Given this list of marker genes Akt2, Erbb2 (NCBI Gene Id 13866), Myo5a, Ap2b1, Stac, Cacng2, Rer1, Musk, Mesd, Stac3, Tnf, Grip2, Acsl3, Stx3, Itgam, Lgals3, Arhgef16, Pak1, Commd1, Itga3, Zdhhc2, Akt1, Snx27, Myo5b, Dpp6, Arpc2, Ezr, Kif5b, Actr3, Slc51b, Gper1 (NCBI Gene Id 76854), Agr2, Rab11fip2, Stac2, Stx4a, Vil1, Epha3, Pik3ca, Tent2, Kcnb1, Chp1 (NCBI Gene Id 80510), Arf6, Necab2, Agrn, Fyn, Crk, Slc5a3, Cln3, Mief2, Cnpy4 (canopy FGF signaling regulator 4), Dlg4, Cemip, C2cd5, Mief1, Prkn, Dlg1, Efcab7, Atp2b4, Hras, Hpca, Mtcl1, Ptpn9, Trem2, Lrp4, Rab11a, Zdhhc5, Cd81, Sqstm1, Cdk5, Dok7 (NCBI Gene Id 231134), Ramp3, Crkl, Clasp2, Prnp, Pls1, Grip1, Itgb1, Lrp1, Myo1c, Pkp1, Egfr, Ppp1r9b, Rac1, Cdk5r1, Nlgn2, Tcaf1, Wnt3a, Grin2a, Rangrf, Rhog, Prkci, Ptn, Wnk3, Nkd2, Ccl2, Kcnj11, Mff, Cacnb3, Pdcd5, Sorbs1 (NCBI Gene Id 75688), Itgb1bp1, Ank3, Atp2c1 (ATPase, Ca++-sequestering), Pdzk1, Pdpk1, Akap5, Cib1, Pgrmc1, Nrxn1, Farp1, Clip3, Lrp5, Fnta, Ephb2, Stom, Ssh1, Pdcd5-ps, Sptbn1, Tnfaip6, Epha2, Cnst, Rack1, Fis1, Dpp10, here is a description of the gene set: Any process that activates or increases the frequency, rate or extent of protein localization to membrane. Mouse Gene Set: GOBP_POSITIVE_REGULATION_OF_PROTEIN_LOCALIZATION_TO_MEMBRANE species: Mus musculus